The following is a description of a gene set: species: Homo sapiens Peripheral arterial stenosis Narrowing of peripheral arteries with reduction of blood flow to the limbs. This feature may be quantified as an ankle-brachial index of less than 0.9, and may be manifested clinically as claudication. Human Gene Set: HP_PERIPHERAL_ARTERIAL_STENOSIS, and this is the list of marker genes: IDS, SMAD2 (NCBI Gene Id 654050), ACTA2, SMAD3, HEY2, MYH11, JAK2, TGFB2, ABCC6, FBN1, THPO, AGXT, TGFBR1, MPL, ABCG5, MYLK, TGFBR2 (transforming growth factor beta receptor 2), LMNA, PCSK9, APOE, APOB, LDLR, LOX, ABCG8, TGFB3, ELN, PRKG1, THSD4, SMAD4, MAT2A, FOXE3, LDLRAP1, MFAP5